The following is a description of a gene set: from publication Cui A, Huang T, Li S, Ma A, Pérez JL, Sander C, Keskin DB, Wu CJ, Fraenkel E, Hacohen N (PMID 38057668) species: Mus musculus Cytokines mediate cell-cell communication in the immune system and represent important therapeutic targets. A myriad of studies have highlighted their central role in immune function, yet we lack a global view of the cellular responses of each immune cell type to each cytokine. To address this gap, the authors created the Immune Dictionary, a compendium of single-cell transcriptomic profiles of more than 17 immune cell types in response to each of 86 cytokines (>1,400 cytokine-cell type combinations) in mouse lymph nodes in vivo. A cytokine-centric view of the dictionary revealed that most cytokines induce highly cell-type-specific responses. For example, the inflammatory cytokine interleukin-1β induces distinct gene programmes in almost every cell type. A cell-type-centric view of the dictionary identified more than 66 cytokine-driven cellular polarization states across immune cell types, including previously uncharacterized states such as an interleukin-18-induced polyfunctional natural killer cell state. Mouse Gene Set: CUI_CDC2_FLT3L_RESPONSE_DN Genes negatively differentially expressed in cell type: cDC2 (conventional dendritic cell type 2) upon treatment with cytokine: FLT3L in mouse lymph nodes in vivo., and this is the list of marker genes: Cd86, Eif3e, Klhl24, Dusp1, Pmaip1, Fos, Junb, Gadd45b, Cox7a2l, Fosb, Fau, Tsc22d3, Pim1 (NCBI Gene Id 18712)